The following is a description of a gene set: Mouse Gene Set: GOBP_ESTABLISHMENT_OR_MAINTENANCE_OF_MICROTUBULE_CYTOSKELETON_POLARITY Any cellular process that results in the specification, formation or maintenance of polarized microtubule-based cytoskeletal structures. studied in species Mus musculus, and this is the list of marker genes: Camsap3, Ckap5, Lmna, Kif2c, Ank3